Given this list of marker genes MFAP1, LAMTOR4, NEK7, UGGT1, HK1, GRIK5, TDP1, ADISSP, ALG2, TRIM11, IFT172, VRK1, FUOM, PLEKHA1, GDPD3, OPA1, RBBP7, LAPTM4A, RASSF3, ENY2, SLC25A39, DNAJC9, GUCA1A (NCBI Gene Id 387091), ZBP1 (Z-DNA binding protein 1), SMPDL3A, F7, KHDRBS2, LYSMD2, CENPV, FKBP11, SMIM14, ITM2B, PRKACA, RPS3A, NGRN (NCBI Gene Id 51335), STK16, FAF1, SELENOP, HLA-DMA, CACYBP, FMC1, CPPED1, SMARCAL1, KIF1C, CORO2A, LARGE1, PARVG, MKNK1, SLC12A9, SARS1, HMGCL, EPB41L5, XPR1 (xenotropic and polytropic retrovirus receptor 1), IDNK, RNF181, KHK (ketohexokinase), NUP88, BLOC1S6, MYL6, MCM7, NDUFA4, IP6K1, PEPD, CD300C, HMBS, HP1BP3, CLNS1A, IL6R, RPRD1A, RACGAP1, ERCC8, CCNG1, MIX23, PLA2G15, ACAA1, TMEM141, ZNF277, CAPZA1, MAST1, CPQ, ABCG2 (NCBI Gene Id 9429), PCNA, RDH14, ITPKA, ENG, POLR2I, PLXDC1, TP53, MRPS35, DGLUCY, MOCS2, RNH1, RPS5, C6orf132, CNOT6L, MBD2, ARRB1, RPE, ADNP, HSBP1, PGP, CXCR6, PLXNB2 (plexin B2), TFEB, ECRG4, ATP5IF1, F8A1, SKIC8, MRPS26 (mitochondrial ribosomal protein S26), MRPL44, DOP1B, POLK, TUBA1A, GYS1 (glycogen synthase 1), SDHAF1, CYP27A1, DPH7 (diphthamide biosynthesis 7), TMEM30A, RNF123, SLC40A1, COPG2, C6orf62, MRPL2, ADRB2, CNOT6, CHCHD7, CCDC77, PRODH, TMEM242, ACBD6, ANLN (anillin, actin binding protein), ACADSB, COA6, HAUS3, TSNAX, HPF1, MFSD6, HEXIM1, GPR146 (NCBI Gene Id 115330), STK24, NEK1, IFIT2, NHEJ1, CCAR2, PYGB, IRF2, SHKBP1, LPGAT1, RAP1A, MTMR3, CCDC28A, C19orf53, ATF6, RBM39, ENTPD1, MX1, MRPS24, SASH3, CORO1A, ZNF444, ADAM11, TANGO2, DOCK1, TXNDC5, GALC, NCAPH, SLC25A45, HOMER1, CMTM6, SLAMF9, CISD1, STMN1, BUB1, APOC2, CXCR4, TALDO1, AAGAB, OSBPL11, GLMN, P2RY12, MTFMT, ZMIZ2, SYNPO, DAB2, DEPDC7, CCNQ, RNF214, POLR2B, BHLHE22, RPL6, FAM149B1, SLC16A4, SEPTIN8, AAAS, C14orf119, CLIC1, UNC119B, LGALS8, ITPR1, MRPL11, here is a description of the gene set: mouse primary BMDCs were stimulated with tlr ligands and gene expression changes were profiled on Affymetrix arrays studied in species Homo sapiens Human Gene Set: GSE17721_CTRL_VS_PAM3CSK4_4H_BMDC_UP Genes up-regulated in comparison of control dendritic cells (DC) at 4 h versus those stimulated with Pam3Csk4 (TLR1/2 agonist) at 4 h. from publication Amit I, Garber M, Chevrier N, Leite AP, Donner Y, Eisenhaure T, Guttman M, Grenier JK, Li W, Zuk O, Schubert LA, Birditt B, Shay T, Goren A, Zhang X, Smith Z, Deering R, McDonald RC, Cabili M, Bernstein BE, Rinn JL, Meissner A, Root DE, Hacohen N, Regev A (PMID 19729616)